Given this list of marker genes Sgcd, Dag1 (NCBI Gene Id 13138), Sgca, Sgcz, Sgcg, Sgce, Sgcb, here is a description of the gene set: A protein complex that includes alpha- and beta-dystroglycan, which are alternative products of the same gene; the laminin-binding component of the dystrophin-associated glycoprotein complex, providing a link between the subsarcolemmal cytoskeleton (in muscle cells) and the extracellular matrix. Alpha-dystroglycan is an extracellular protein binding to alpha-laminin and to beta-dystroglycan; beta-dystroglycan is a transmembrane protein which binds alpha-dystroglycan and dystrophin. studied in species Mus musculus Mouse Gene Set: GOCC_DYSTROGLYCAN_COMPLEX